Given this list of marker genes SLC34A1, SLC34A3, CLCN5, KL, VDR, GALNT3, here is a description of the gene set: Human Gene Set: HP_HIGH_SERUM_CALCITRIOL species: Homo sapiens An increased concentration of calcitriol in the blood. Calcitriol is also known as 1,25-dihydroxycholecalciferol or 1,25-dihydroxyvitamin D3. High serum calcitriol